The following is a description of a gene set: The organelle membrane fusion process in which the membrane of a multivesicular body fuses with a lysosome to create a hybrid organelle. Human Gene Set: GOBP_MULTIVESICULAR_BODY_LYSOSOME_FUSION studied in species Homo sapiens, and this is the list of marker genes: CHMP2B (NCBI Gene Id 7877), CHMP4A, RUFY4, CHMP4C, CHMP7, CHMP3, CHMP2A, CHMP5, CHMP1B, CHMP6, CHMP4B, CHMP1A